Given this list of marker genes KBTBD8, ZNF687, DDX39B, KIF1B, CEP135, CD68, CREM, RAB22A, SLC25A4, TNR, HOXC10, POPDC2, AKIRIN2, GRIK2, ZZZ3, RALGDS, CDH10, RAB1B, UBR3, DLX1, PHF6, CSDE1, VSNL1, ANKRD17, LUC7L2, PRKACA, RBM39, KRTAP13-2, DAP3, FBXW7, PRM1, FAM193B, TSPAN13, MAP3K20, ACTG2, SCML4, RGSL1, EML4, WNT3, TTLL11, DYNC2I2, SYNCRIP, TSSK3, SCN3A, GTF2A1 (NCBI Gene Id 50857), CDH20, NR2C2, ZNF654, PRKAG1, KCNT2, FAF1, ZEB2, DNASE2B (deoxyribonuclease 2 beta), SELENOT, GPR162, SRSF2, PEX7, NCDN, C5, CDKL5, SETD2, DIDO1, PCBP4, YPEL3, PHOX2B, BPTF, CALHM4, RAB8B, PDZRN4, CUTA, CTDSP1, FAM117A, CXADR, YY1AP1, FBXW11, EGR3, RHOA, SRRM2, TSSK1B, TAL2 (TAL bHLH transcription factor 2), DDAH1, TAOK2, EGR2, E2F3, DUSP7, HIC2, IP6K2, PTGR3, SOX14, PHF12, CALD1, NRAS, CD4, SOBP, MIR1-1HG, ZNF41, AP1G1, SRF, SRGAP2, PDE4D, IL17B, GFRA3, CHM, ZNF711, RNF44, DNAJB4, PBX3, DUSP10, MYL1, PRDM10, BNC2, MATR3, CD3E, RBMX, ID1, PCYT2, RBM4B, DPAGT1, TPM1, RNF43, ECEL1, GBF1, EPS8L1, NCAM2, CABCOCO1, ZNF668, CCN1, OPRM1, CCSER2, UBE3A, GPBP1, ACTN1, SNAP25, TCTA, TLK2, IST1, TENM1, YWHAE, ING4, ASH1L, RGS12, HNRNPC, PPP2R2A, NPAS4 (neuronal PAS domain protein 4), FUS, CCDC25, TLE3, CACNB2, DDX3X, LUC7L3, MYH11, TCF4, WTAP, NFE2L1, ACVR2A, PTBP3, CRMA, CHD2, ZFP91, PPP2R2B, MAP4K5, ATP5MC2, ADK, NAT8L, MED24, ZNF547 (zinc finger protein 547), PAFAH1B1, ZNF747, PFN2, PLAG1, CASQ1, HOXD10, KIT, GRIN2B, SRSF3, CLVS1, RELA, FLRT3, FHL3, PCF11, CCR3, PWWP2B, SIAH3, CTCF, ATP6V0B (NCBI Gene Id 533), SEC23B, RBMS1, CHCHD7, CAST, RHOJ, SPRY4, PRICKLE3 (prickle planar cell polarity protein 3), RAB1A, FOXP2, BEX3, DSTN (NCBI Gene Id 11034), GABRA1, MYO18A (myosin XVIIIA), MYF5 (myogenic factor 5), DDX6, LCP2, DLG3, CASQ2, SLC25A13, FOS, PLXNB1, ZNF688, KMT2E, FSIP2, GNAI2, MLIP, RPIA, UBE4B, PRR34, ZNF644, NLN, KLHL23, EN1, GTF3C2 (general transcription factor IIIC subunit 2), INPPL1, TFAP4, STRIP1, TMEM69, EPC1, CDH6, ZNF646, ZPBP2, ARFGEF1, SGTB, KIRREL2, ATP10B, CBX4, PHF8, MYO1E, HMGB2, PRIMA1, MIR503HG, STAG1, HAPSTR1, TAFAZZIN, TPM3 (tropomyosin 3), PRKAB2, AKAP8L, TRAF3, LHX9, SNX13, PPP2R5C, SSH2, ARMCX3, ADNP, CACNA2D3, NETO1, here is a description of the gene set: Genes having at least one occurrence of the motif NNNNNCCATNTWNNNWN in the regions spanning 4 kb centered on their transcription starting sites. This matches the YY1 transcription factor binding site V$YY1_01 (v7.4 TRANSFAC). studied in species Homo sapiens Human Gene Set: YY1_01